The following is a description of a gene set: A transcription initiation process that takes place at a RNA polymerase I gene promoter. Ribosomal RNAs (rRNA) genes are transcribed by RNA polymerase I. studied in species Homo sapiens Human Gene Set: GOBP_TRANSCRIPTION_INITIATION_AT_RNA_POLYMERASE_I_PROMOTER, and this is the list of marker genes: RRN3, TAF1B, TBP, TTF1, SMARCB1, RRN3P2, RRN3P1, TAF1, SMARCA4, UBTFL1, POLR1G, BAZ2A, POLR1E, CAVIN1, UBTFL6, UBTF, TAF1C